The following is a description of a gene set: The dynamics and molecular mechanisms underlying vaccine immunity in early childhood remain poorly understood. Here we applied systems approaches to investigate the innate and adaptive responses to trivalent inactivated influenza vaccine (TIV) and MF59-adjuvanted TIV (ATIV) in 90 14- to 24-mo-old healthy children. MF59 enhanced the magnitude and kinetics of serum antibody titers following vaccination, and induced a greater frequency of vaccine specific, multicytokine-producing CD4(+) T cells. Compared with transcriptional responses to TIV vaccination previously reported in adults, responses to TIV in infants were markedly attenuated, limited to genes regulating antiviral and antigen presentation pathways, and observed only in a subset of vaccinees. In contrast, transcriptional responses to ATIV boost were more homogenous and robust. Interestingly, a day 1 gene signature characteristic of the innate response (antiviral IFN genes, dendritic cell, and monocyte responses) correlated with hemagglutination at day 28. These findings demonstrate that MF59 enhances the magnitude, kinetics, and consistency of the innate and adaptive response to vaccination with the seasonal influenza vaccine during early childhood, and identify potential molecular correlates of antibody responses. from publication Nakaya HI, Clutterbuck E, Kazmin D, Wang L, Cortese M, Bosinger SE, Patel NB, Zak DE, Aderem A, Dong T, Del Giudice G, Rappuoli R, Cerundolo V, Pollard AJ, Pulendran B, Siegrist CA (PMID 26755593) Genes up-regulated in peripheral blood mononuclear cell 1d postboost vs 0d pre-imm in children (14-27m) (MF59-adjuvanted) after exposure to Fluad, time point 1D. Comment: ATIV Human Gene Set: NAKAYA_PBMC_FLUAD_MALE_AGE_14_27YO_1D_POSTBOOST_VS_0D_PREIMM_MF59_ADJUVANTED_1DY_ATIV_UP studied in species Homo sapiens, and this is the list of marker genes: ATF3, OAS3, CXCL10, ETV7, LAMP3, IFI35, VAMP5, PSTPIP2, MYOF, EFCAB2, STAT1, LHFPL2, IDO1, RSAD2, CALHM6, GBP4, TFEC, KREMEN1, SCARF1, LAP3, SORT1, CEACAM1, SMCO4, IFI44L, TYMP, P2RY14, CD274, FCGR1BP, GK, EPSTI1, WARS1, SERPING1, IL15, ANKRD22, BATF2, ICAM1, FBXO6 (NCBI Gene Id 55822), GBP5, GBP1, FCGR1A